Given this list of marker genes Jak3, Il2, Hmgb1, Lgals1, Ndfip1 (Nedd4 family interacting protein 1), Rc3h2, Bcl6, Irf1, Tbx21, Cd69, Tnfrsf14, Anxa1, Cd274, Tnfsf4, Xcl1, Itch, Tnfsf18, Vsir, Zc3h12a, Arg2, Smad7, Cbfb, Cblb, Runx3, Pf4, Hlx, Loxl3, Socs5, Tarm1, Rc3h1, Runx1, Il4ra, Il4, Zfp35, Foxp3, Lgals9, Twsg1, Cd44, Zbtb7b, Ascl2, here is a description of the gene set: Mouse Gene Set: GOBP_NEGATIVE_REGULATION_OF_CD4_POSITIVE_ALPHA_BETA_T_CELL_ACTIVATION Any process that stops, prevents or reduces the frequency, rate or extent of CD4-positive, alpha-beta T cell activation. species: Mus musculus